Given this list of marker genes Ehmt1, L3mbtl2, Chek1, Rbbp7, Ring1, Mga, E2f6, Pcgf2, Suz12, Phc3, Yaf2, Rybp, Max, Ehmt2, Eed (NCBI Gene Id 16759), Rbbp4, Epc1, Phc1, Bmi1, Pcgf6, Rnf2, Tfdp1, Ezh2, here is a description of the gene set: studied in species Mus musculus Mouse Gene Set: REACTOME_TRANSCRIPTIONAL_REGULATION_BY_E2F6 Transcriptional Regulation by E2F6